Given this list of marker genes MIR873, BMPR1A, MIR19B1, MIR199A1, MIR548C, MIR1-1, HEY2, WNT2, RBP4, TBX2, TP73, MIR17HG, MAPK11, TGFBR1, MEF2C, MIR199B, PIM1, TBX20, MAPK14, MIR590, GATA6, RUNX1, MIR200B, FGFR2, CDK1, BMP10, MIR204, CCNB1, ERBB4, SAV1, VGLL4 (vestigial like family member 4), NKX2-5, NOG, YAP1, MIR509-1, TBX5, FGFR1 (NCBI Gene Id 84151), MIR222, NRG1, ZFPM2, RBPJ, JARID2, NOTCH1, TGFBR3, FGF2, KCNK2, FGF9, FGF20, GLI1, here is a description of the gene set: Any process that modulates the frequency, rate or extent of cardiac muscle cell proliferation. species: Homo sapiens Human Gene Set: GOBP_REGULATION_OF_CARDIAC_MUSCLE_CELL_PROLIFERATION